Given this list of marker genes ZBTB16, IL12B, IL18, IL2, IHH, EP300, BATF, SHH, CD80, NCKAP1L, CCL19, ADA, HMGB1, IRF4, GLI3 (GLI family zinc finger 3), LOXL3, PNP, NKAP, CD69, SASH3, ANXA1, IL4R, LILRB4, ZC3H12A, HLA-DRB1, ZAP70, HLX, RIPK2, ZNF683, OPA1, MALT1, NLRP3, LGALS1, AP3D1, AP3B1, TGFBR2, CD86, LGALS9, SOCS5, TBX21, KCNK18, SYK, GATA3, NFKBIZ, NFKBID, ZBTB7B, STAT5A, SH3RF1, CD83, IL2RG, PRKCZ, IL27, SMAD7, TNFSF18, FOXP3, SHB, IL12RB1, BCL6, JAK3, HLA-DRA, RC3H2, TNFSF4, IFNG, PRDM1, SOCS1, ASCL2, RUNX3, RHOA, SLC4A2, JUNB, IL23R, RC3H1, BRD2, GPR65, CBFB, MIR21, RUNX1, ITPKB, KLHL25, BRD4, IL23A, RARA, here is a description of the gene set: species: Homo sapiens Any process that modulates the frequency, rate or extent of alpha-beta T cell differentiation. Human Gene Set: GOBP_REGULATION_OF_ALPHA_BETA_T_CELL_DIFFERENTIATION